The following is a description of a gene set: species: Mus musculus The chemical reactions and pathways resulting in the formation of alcohols, any of a class of compounds containing one or more hydroxyl groups attached to a saturated carbon atom. Mouse Gene Set: GOBP_ALCOHOL_BIOSYNTHETIC_PROCESS, and this is the list of marker genes: Akr1b1, Paqr3, Asah2, Por, Pgp, Mbtps2, Apob, Cyp51, Lep, Lhcgr, Sphk2, Hsd17b7, Apoa1 (apolipoprotein A-I), Ces1b, Cftr, G6pd2, P2ry6, Sptlc3, Tm7sf2, Ces1c, Pts (6-pyruvoyl-tetrahydropterin synthase), Ces1d, Ces1a, Sod1, Clcn2, Plek, Fgf1, Fdps, Npc1l1, Itpkb, Gpr146, Qki, Sptlc1, Mapk1, Cyb5r3, Pth1r, Ces1g, Dkk3, Prkaca, Sec14l2, Ip6k2, Idi2, Ces1h, Bmp6, Ip6k3, Agk, Ip6k1, Got1, Rest, Erlin1, Bmp5, Mvk, Cacna1h, Mas1, H6pd, Npy1r, Abcg4, Asah1, Cyp2r1, Srebf2, Erlin2, Prkaa2, Sptssb, Cyp27a1, Ces1f, Lpcat3 (NCBI Gene Id 194356), Pcbd1, Prkg1, Acer2, Dhdds, Adcyap1r1, Dhcr7, Pmvk, Acer1, Snca, Avpr1b, Aqp8, Bmp2, Ppip5k1, Dbh, Impa2, 3110082I17Rik, Sptlc2, Pex2, Nfkb1, Isyna1, Itpka, Cyp27b1, Pcbd2, Moxd1, ENSMUSG00000144291, Plcg2, Itpkc (inositol 1,4,5-trisphosphate 3-kinase C), Gch1, Cd244a, Insig1, Msmo1, Nus1, Qdpr, Hmgcs1, Park7, G6pdx, Pck1, Gper1, Ebp, Hmgcr, Dhfr, Ntsr1, Ptafr, Cyp11b2, Abcg1, P2ry1, Ppip5k2, Ephx1, Insig2, Impa1, Wnt4, Scp2, Cyp7a1, Sphk1, Cyp11b1, Ippk, Ces1e, Ipmk, Myh9, Lbr, Acer3, Dgkq, Scap, Pck2, Srebf1, Lipa (lysosomal acid lipase A), Srd5a3, Plcg1 (NCBI Gene Id 99130), Pth, Dab2, Gba1, Pou1f1, Lss, Sptssa, Gnai1, Prkaa1, Dhcr24, Spr, Plcd1, Gfi1, Moxd2, Nsdhl, Mvd (NCBI Gene Id 97454), Idi1, Fdft1, Abca2, Hmgcs2, Sc5d, Cyp24a1, Apoe